The following is a description of a gene set: Human Gene Set: GOBP_TRANSCRIPTION_DEPENDENT_TETHERING_OF_RNA_POLYMERASE_II_GENE_DNA_AT_NUCLEAR_PERIPHERY The chromosome organization process in which the DNA sequence containing a gene transcribed by RNA polymerase II is maintained in a specific location at the nuclear periphery. In S. cerevisiae, this process involves cis-acting DNA sequences such as the TATA box and upstream activating sequence (UAS) elements, trans-acting transcriptional activators, and also the 3'-UTR of the transcript. studied in species Homo sapiens, and this is the list of marker genes: NUP155, NUP133, RAE1, NUP98, LDB1, PCID2, NUP107